Given this list of marker genes Tbc1d7, Lpar1, Lima1, Wdr44, Mphosph9, Tbc1d30, Marchf7, Trim32, Yap1, Evi5l, Cep97, Cdk10, Akt1, Luzp1, Tesk1, Odf2l, Limk2, Ccp110, Dnm2, Mak, Tchp, Kif24, Gdi2, here is a description of the gene set: studied in species Mus musculus Mouse Gene Set: GOBP_NEGATIVE_REGULATION_OF_CILIUM_ASSEMBLY Any process that stops, prevents or reduces the frequency, rate or extent of cilium assembly.